The following is a description of a gene set: part of: Differentiation of T cells Naive (unexposed to antigen) CD4+ T cells are induced to differentiate into T helper 2 cells (Th2 cells) by encounters with dendritic cells presenting antigen peptides on MHC II complexes. Antigen peptides activate signaling by the T cell receptor (TCR) which is amplified by the interaction between CD80 or CD86 on the dendritic cell and CD28 on the T cell. Dendritic cells also secrete cytokines that determine the differentiation of CD4+ T cells into various helper and regulatory subtypes, a process called polarization.<br>The specific cytokine secreted by dendritic cells to initiate Th2 differentiation is not conclusively known but may be Interleukin-2 (IL2). IL2 from either dendritic cells or T cells activates signaling in the T cell that yields phosphorylated STAT5 dimers. The STAT5 dimers bind and activate the gene encoding IL4R, a receptor subunit for IL4, and cause opening of chromatin at the IL4 locus. IL4 signaling in the CD4+ T cell produces phosphorylated STAT6 dimers that bind the gene encoding GATA3, the master regulator of Th2 differentiation.The STAT6 dimers also bind a locus control region (LCR) in the 3' region of the RAD50 gene, which is located in a gene cluster that contains genes encoding the Th2 cytokines IL4, IL5, and IL13, and promote their expression. Expression of GATA3 is also activated by NFATC2 (NFAT1), from TCR signaling (Scheiman and Avri et al. 2009), and NICD1 and NICD2, from Notch signaling.<br>GATA3 is sufficient to direct Th2 differentiation, including expression of Th2-characteristic cytokines. GATA3, STAT6 dimers, and other factors bind the LCR and recruit chromatin modifiers to open chromatin in the region by acetylating histones. <br>Th2 cells are characterized by the expression and secretion of the cytokines IL4, IL5, and IL13, which are encoded by genes located with the LCR in a cluster on human chromosome 5 (chromosome 11 in mice). GATA3, NFATC2 and other factors bind the promoters of the IL4 gene and IL13 gene and activate expression. GATA3 binds the IL5 gene and can activate or repress it expression, depending on the binding site. studied in species Homo sapiens Reactome Pathway: Differentiation of naive CD4+ T cells to T helper 2 cells (Th2 cells), and this is the list of marker genes: PHC1, PHC3, NCOR1, IL4R, CBX6, RING1, GATAD2A, KAT2A, CHD3, SATB1, NCOR2, KAT2B, MAF, RBPJ, RBBP7, TBX21, MAML3, RAD50, GATAD2B, IL13, HDAC3, MAMLD1, JUN, TBL1X, YY1, POU2F1, BATF, RNF2, SCMH1, CREBBP, HDAC1, NOTCH2, ETS1, EP300, MBD3, SNW1, HDAC6, MTA2, CBX4, MAML2, BMI1, RBBP5, HDAC5, NOTCH1, STAT5A, NFATC2, HDAC7, RBBP4, IL4, HDAC4, IL5 (NCBI Gene Id 3567), CBX8, CBX2, HDAC11, STAT5B, MAML1, GATA3, MTA3, ASH2L, DPY30, HDAC2, TBL1XR1, HDAC9, SMARCA4, IRF4, KLF13, STAT6, WDR5, KMT2A, FOS, MEN1, HDAC8, MTA1 (NCBI Gene Id 9112), HDAC10, CHD4, PHC2, POU2F2